The following is a description of a gene set: species: Homo sapiens Human Gene Set: AIZARANI_LIVER_C20_LSECS_3 from publication Aizarani N, Saviano A, Sagar, Mailly L, Durand S, Herman JS, Pessaux P, Baumert TF, Grün D (PMID 31292543), and this is the list of marker genes: TMEM51, CDKN1A, FLT1, PTPN1, NOLC1, CDH5, BHLHE40, PRCP, TCIM, DNMBP, KDR, TCERG1, CLEC4G, PHC2, SHROOM4 (shroom family member 4), SLC7A8, ASAP1, NID1, LUZP1, SHANK3, PDE2A, OIT3, KLF7, SERPINE1, SSH1, TGM2, RALA, NRP1, RRBP1, NOTCH4, CHSY1, ADAMTS4, CDC42BPB (CDC42 binding protein kinase beta), STC1, PRKD3, C11orf96, ZEB2, ARHGEF7, GRB10, TANC1 (tetratricopeptide repeat, ankyrin repeat and coiled-coil containing 1), RHOJ, SGK1, JUND, CD59, PLEKHG1, BAZ1A, ACKR3, MAST4, PEA15, ERG, ESAM, DNTTIP2, GPRC5A (G protein-coupled receptor class C group 5 member A), PPFIBP1, AFF4, NCOA7, ROCK2, WDR43, STC2, SBNO2, GOLGA4, EPAS1, IL33, NRIP1, TGFBR3, PREX2, EFNB2, MARCHF3, RAPGEF5, NCL, PRSS23, ETS2, TCF7L2, PNP, PCDH17, FKBP1A, ACTN1, OSMR, HIF1A, EIF5B, CRIM1, MID1, SEMA6A, TNFRSF10B, LYVE1, CLEC4M, LIMCH1, ZEB1, ROBO4, NDRG1, ITGA9 (NCBI Gene Id 3680), GOLGB1, CUL4B, MARCKSL1, DAAM1, SRGAP1, GALNT1, CDC37, ADGRL4, NOS3, FCN3, SEMA3F, PLPP3, DNASE1L3, PLCB1, RDX, CXCL16, SORBS1, STAB2, ZNF462, RASIP1, BNIP3L, HERC1, TNFRSF10D (NCBI Gene Id 8793), TIMP3, PLAUR (plasminogen activator, urokinase receptor), UGCG, SLC2A3, PVR, TM4SF1, TOX2, AKAP12, ITPKC, JAM3, CAMSAP2, ADAMTS1, MARCKS (NCBI Gene Id 4082), RBBP6, S1PR1, FOSL2, NFKBIA, S100A16, ADAMTS9, IFI27, MACF1, IFI16, MTCL2, ADGRF5, HYAL2, INSR, SEC14L1, USP13, TINAGL1, VCL (NCBI Gene Id 7414), B4GALT5, RELN, AHCTF1, CCL15-CCL14, CDK17, BTNL9, STAB1, SERPINH1, TUBB6, FGFR1, MYO10, CD9, TCF4, C5AR2, CHD7, FXYD6, FGF23, TIE1, TFPI, YES1, DYNC2I1, STX12, CNKSR3, PLTP, IGFBP7, PAPSS2, BMPR2, THBD, CAVIN2, TFPI2, LDB2, WARS1, SLC4A7, UPP1, F8 (coagulation factor VIII), LMNA, RBM25, SNRK, KCTD20, IVNS1ABP, HPCAL1, DAB2, ARHGAP26, FAM107A (NCBI Gene Id 50803), ITGA5, IL1RL1, EEA1, HIPK2, COL4A1, NXPE3, SOX7, CRHBP, CAVIN1, ARHGAP23, DLC1, MRO, UACA, NAMPT, ACP5, COL4A2, IL1R1, SLC7A1, SLC20A1, FOSL1, CCDC50, HIC1 (NCBI Gene Id 3090), PRICKLE2, MIR4435-2HG, MCAM, SASH1, TOP1, SPRY4, SNX9, RPGR, CLEC1B, MAP1B, EMP1, FLNB, DUSP6, BDP1, SOCS3, KDM6B, CEMIP2, IL6ST, TIMP1, JMJD1C, FAM43A, LGMN, NR5A2, MYCT1, SPARC, ADAM9, PTPRB, LIFR, ANKRD11, SDCBP, APOLD1, PEAK1, SLCO4A1, TAL1, ANGPTL4, ADM, ICAM1, SPAG9, CTSL, CD14, PLXNA2, FILIP1, LIMA1, GARRE1, PXDN, CD93, SLC25A37, SOX17, NAV1 (neuron navigator 1), PXN, MRC1, RAI14, FNDC3B, NR2F1, RBMS1, ARGLU1, MEG3, WWTR1, DDX3Y, DUSP5, APP, CEP170, C1QTNF1, CD36, IL4R, WSB1, LRRC32, PDLIM1, RIPOR1, FCN2, NRP2, RBM17, FOXC1, YBX3, ARSG, ENG, PIEZO2, CCDC144A, DCUN1D3, ITPRIP, ARHGAP29, DDX21, CSNK1E, ZNF160, PPP1R15A